Given this list of marker genes PRKCA, FOSL2, IBSP, ARNT, P4HTM, CNMD, RELB, JAK2, LAMTOR1, AKT3, COL1A1, DIO2, COL2A1, COL10A1, MAPK3, CEBPB, FGF23, COL3A1, FGFR2, NGF, FGFR4, NFKB1, JUND, EPAS1, SPP1, RUNX2, GANC, JUNB, KDR (kinase insert domain receptor), VHL, JUN, MAPK1, FOSB, FGFR3, PIK3CA, FGFR1, FOSL1, DDR2, STAT3, HIF1A, ACAN, SOX9, RELA, CCN2 (NCBI Gene Id 1490), VEGFA, MMP13, NTRK1, FOS, AKT2, AKT1, here is a description of the gene set: Human Gene Set: WP_OSTEOARTHRITIC_CHONDROCYTE_HYPERTROPHY studied in species Homo sapiens Osteoarthritic chondrocyte hypertrophy